The following is a description of a gene set: Any process that results in a change in state or activity of a cell or an organism (in terms of movement, secretion, enzyme production, gene expression, etc.) as a result of a mechanical stimulus. Mouse Gene Set: GOBP_RESPONSE_TO_MECHANICAL_STIMULUS species: Mus musculus, and this is the list of marker genes: Tacr1, Lrp11, Mir495, Ptn, Il18, Ano1, Dag1, Scn11a, Rest, Gata4, Il33, Ucn, Mir3092, Mapk14, Edn1, Ptprq, Grm8, Scn1a, Atp8a2, Tmem150c, Slc26a5, Asns, Eng, Mir652, Ddr2, Atp1a2, Pkd2, Tmc1, Mir376a, Irf1 (interferon regulatory factor 1), Scx (NCBI Gene Id 20289), Pkd2l2, Foxp2, Pkd1l1, Egfr, Psph, Raf1, Kcnq3, Slc38a2, Mir379, Smpd2, Mir5621, Mir143, Ankrd23, Stra6, Pkd1, Nrxn1, Endog, Mir208a, Ripor2, Gap43, Tlr8, Atp2b2, Btg2, Txnip, Piezo1, Adgrv1, Clcn6, Col3a1, Nrxn2, Fgf2, Itgb3, Map1b, Ednra, Kcnk2 (potassium channel, subfamily K, member 2), Pik3ca, Habp4, Chuk, Slc9a1, Kcna5, Aqp1, Ccl2, Bag3, Gja1, Cxcl12, Drd2, Serpine2, Ptch1, Shank3, Angpt2, Gfi1, Cxcr4, Fadd, Krt5, Slc2a1, Whrn, Slitrk6, Dmd, Mmp14, Tmem120a, Tgfb1, Nos3, Pdzd7, Mbd2, Jup (NCBI Gene Id 16480), Thbs1, Capn2, Bdkrb1, Cd40, Scel, Chek1, Mapk3, Got1, Ankrd1, Kcnj2, Tnfrsf1a, Mir1192, Gsn, Sox9, Ntrk1, Mir301, Hpn, Sost, Asic2, Gadd45a, Mag, Mir300 (microRNA 300), Sun1, Pkd1l3 (NCBI Gene Id 244646), Fyn, Tnc, Map3k14, Rac1, Bad, Grin2a, Strc, Ptk2b, P2ry1, Oxt, Pax2, Casp2, Fosb, Ptpn11, Mir3473c, Mir26a-2, Bcl10, Slc1a3, Postn, P2rx7 (NCBI Gene Id 18439), Csrp3, Akt1, Rela, Kcna1, Mir148b, Chi3l1, Strbp, Asic3, Myd88, Lck, Mir214, Bace1, Fosl1, Wnt11, Tlr7, Plec, Trpa1, Chrna9, Cited2, Mir26a-1, Mir1895, Mkks, Mkx, Pde2a, Mir101b, Igf1, Nfkb1, Col6a1, Slc8a1, Scn9a, Cntnap2, Bak1, Atoh7, Col1a1, Cradd, Nfkbia, Scn10a, Atat1, Piezo2, Htr2a, Kcnk4, Abl2, Nos1, Mir695, Etv1, Bmp6, Rps6kb1, Bnip3, Tmc2, Col11a1, Gdf5, Kcnc1, Pkd1l2, Htt, Mir665, Cav3, Grin2b, Atr, Fos, Calb1, Igfbp2, Kcnq2, Mir194-2, Mir125b-1, Mdk, Ptgs2, Src, Tlr4, Sox2, Cnn2, P2rx3, Mpo, Il1b, Gsk3b, Kit, Htr7, Mir92-2, Mir691, Chrna10, Mmp2, Pawr, Ptger4, Itga2, Xpc, Neurog1, Tuba1a, Phf24, Large1, Tnfrsf11a, Usp53, D130043K22Rik, Ankrd2, Map2k4, Ryr2, Jun, Tmem87a, Ihh, Chrna5, Arhgdia, Ltbr, Tcap, Pcdh15, Mir5128, Slco1b2, Tlr3, Pjvk, Meis2, Pkd2l1, F11r, Tifab, Acta1, Mir410, Mir154 (microRNA 154), Ttn, Slc12a2, Mtpn, Tnfsf14, Cacnb3, Ano3, Mir760 (NCBI Gene Id 791077), Myc, Pkdrej, Mir511, Atp1a1, Lhfpl5, Gpi1 (NCBI Gene Id 676974), Grin2d, Tnf, Abhd12, Cav1, AU040320, Kcnq1, Mapk8, Gclc, Ctnnb1